The following is a description of a gene set: species: Homo sapiens Human Gene Set: MOTAMED_RESPONSE_TO_ANDROGEN_UP Genes up-regulated in ovarian epithelial cells in response to dihydrotestosterone (DHT). Epidemiological studies have implicated androgens in the etiology and progression of epithelial ovarian cancer. We previously reported that some androgen responses were dysregulated in malignant ovarian epithelial cells relative to control, non-malignant ovarian surface epithelial (OSE) cells. Moreover, dysregulated androgen responses were observed in OSE cells derived from patients with germline BRCA-1 or -2 mutations (OSEb), which account for the majority of familial ovarian cancer predisposition, and such altered responses may be involved in ovarian carcinogenesis or progression. In the present study, gene expression profiling using cDNA microarrays identified genes differentially expressed in response to continuous androgen exposure in OSEb cells and ovarian cancer cells as compared to OSE cells derived from control patients. A subset of these differentially affected genes was selected and verified by quantitative real-time reverse transcription-polymerase chain reaction. Six of the gene products mapped to the OPHID protein-protein interaction database, and five were networked within two interacting partners. Basic leucine zipper transcription factor 2 (BACH2) and acetylcholinesterase (ACHE), which were upregulated by androgen in OSEb cells relative to OSE cells, were further investigated using an ovarian cancer tissue microarray from a separate set of 149 clinical samples. Both cytoplasmic ACHE and BACH2 immunostaining were significantly increased in ovarian cancer relative to benign cases. High levels of cytoplasmic ACHE staining correlated with decreased survival, whereas nuclear BACH2 staining correlated with decreased time to disease recurrence. The finding that products of genes differentially responsive to androgen in OSEb cells may predict survival and disease progression supports a role for altered androgen effects in ovarian cancer. In addition to BACH2 and ACHE, this study highlights a set of potentially functionally related genes for further investigation in ovarian cancer. from publication Motamed-Khorasani A, Jurisica I, Letarte M, Shaw PA, Parkes RK, Zhang X, Evangelou A, Rosen B, Murphy KJ, Brown TJ (PMID 16832351), and this is the list of marker genes: GRIA2, SSH1, SSPOP, IDS, MAP3K8, CYP4B1